The following is a description of a gene set: Ventral hernia Ventral hernia refers to a condition in which abdominal contents protrude through a weakened portion of the abdominal wall. Human Gene Set: HP_VENTRAL_HERNIA species: Homo sapiens, and this is the list of marker genes: POGZ, EFEMP1, TWIST2, NXN, AEBP1